Given this list of marker genes NPRL3, INSIG1 (insulin induced gene 1), WNT5A (NCBI Gene Id 7474), PDGFRA, SUMO1, BCOR, ALX1, MMP25, B3GLCT, GDF11, WNT7A, DLX6, IFT172, ANP32B, WNT8A, INSIG2, LOXL3, GABRB3, TGFB2, COL2A1, TGFB3, COL11A2, EPHB3, CSRNP1, GLI3, INTU, FRAS1, DLX5, TGFBR3, SOS1, ITGB6, VAX1, ALX4, WFIKKN1, OSR1, LEF1, TMEM107, WNT3A, OSR2, WNT11, IRF6, MEOX2, TSHZ1, DLG1, CHD7, MSX1, PRRX1, DHRS3, SMAD4, CLDN5, TGFBR2, SATB2, PLEKHA1, SMAD2, SHH, SKI, SNAI1, SOX11, TBX3, SNAI2, TBX2, PAK1IP1, ITGB8, WDPCP, FOXF2, FOXE1, FZD1, BNC2, WFIKKN2, MSC, JAG2, ARID5B, TCF21, PYGO2, ASPH, HAND2, FZD2, BBS7, TIPARP, TGFBR1, TBC1D32, PKDCC, BMPR1A, SGPL1, CDK20 (NCBI Gene Id 23552), TFAP2A, INHBA, ACVR2B, EPHB2, WNT9B, LRRC32, TBX1, here is a description of the gene set: Human Gene Set: GOBP_ROOF_OF_MOUTH_DEVELOPMENT species: Homo sapiens The biological process whose specific outcome is the progression of the roof of the mouth from an initial condition to its mature state. This process begins with the formation of the structure and ends with the mature structure. The roof of the mouth is the partition that separates the nasal and oral cavities.